Given this list of marker genes BTC, EREG (epiregulin), NRG4, EGF, NRG2, ERBB3, ERBB2, EGFR (NCBI Gene Id 1956), HBEGF, NRG1, NRG3, PTK6, ERBB4, here is a description of the gene set: studied in species Homo sapiens part of: Signaling by ERBB2; Signaling by PTK6 PTK6 (BRK) is activated downstream of ERBB2 (HER) and other receptor tyrosine kinases, such as EGFR and MET. However, it is not clear if MET and EGFR activate PTK6 directly or act through ERBB2, since it is known that ERBB2 forms heterodimers with EGFR, and MET can heterodimerize with both EGFR and ERBB2. Reactome Pathway: ERBB2 Activates PTK6 Signaling